The following is a description of a gene set: Apoptosis is mediated by caspases, cysteine proteases arranged in a proteolytic cascade. species: Homo sapiens Human Gene Set: SA_CASPASE_CASCADE, and this is the list of marker genes: PRF1, CASP3, PARP1, SREBF2, BIRC2, CASP7, BIRC3, APAF1, FAS, CASP8, CASP9, DFFB, SREBF1, SCAP, FASLG, DFFA, XIAP, GZMB, CASP10